Given this list of marker genes Cd47, Hspa1a (NCBI Gene Id 193740), Fos, Grap, Rabgap1l, Evl, Mxd4, Arhgap15, Cmah, Rgs10, Txnip, Cirbp, Ifngr1, Txk, Npc2, Pdcd4, Smc4, 9930111J21Rik2, Pik3ip1, Tmem50a, Hspa1b, Rapgef4, Jak1, Myl12b, Stk4, AB124611, Klhl24, Klf6, Sell, Zbtb20, Map4k4, Ube2b, Hp1bp3, Cdkn1b, Lsp1, Hcst, Epsti1, Kif21b, Chd2, Bnip3l, Rhoh, Cd3g, Dapl1, Akap13, Tcf7, Ppp1r15a, Jmjd1c, Klf2, Itga4, Madd, Btg2, Smap2, H1f2, Pcmtd1, Zfp36l2, Atp1b3, Eef1a1, S1pr1, Cd8b1, Slfn2, Tent5a, Plcxd2, Mgst2 (NCBI Gene Id 211666), Ets1, Acp5 (acid phosphatase 5, tartrate resistant), Tmem59, Fam169b, Crip1, Gpx4, Peli1, Cdkn2d, Il7r, Tnrc6b, Ccr9, Jun, Ypel3, Entrep3, Ighm, Smad7, Crlf3, Arhgap45, Dap, Rnf167, Gmfg, Actn1, Saraf, Stk38, Stim1, Zfp36l1, Pnrc1, Scp2, Klrd1, Cd7 (CD7 antigen), Tmem71, Jakmip1, Arl5c, Utrn, Klf3, Tcp11l2, Gimap1, Fau, Rasgrp2, Itm2b, Smpdl3a, Paip2, Fyb1, Cox7a2l, S100a10, Vgll4, Add3, Grap2, Junb, Tspan32, Adcy7, Macf1, Emp3, H2az2, Slamf6, Tsc22d3, Ptpn18, Lef1, Tspo, Sh2d1a, Pold4, Themis, Dguok, Dgka, Selplg, Cd69, Ltb, Btg1, Cxcr4, Cd28, here is a description of the gene set: Genes negatively differentially expressed in cell type: CD8+ T cell upon treatment with cytokine: IL-2 in mouse lymph nodes in vivo. studied in species Mus musculus Cytokines mediate cell-cell communication in the immune system and represent important therapeutic targets. A myriad of studies have highlighted their central role in immune function, yet we lack a global view of the cellular responses of each immune cell type to each cytokine. To address this gap, the authors created the Immune Dictionary, a compendium of single-cell transcriptomic profiles of more than 17 immune cell types in response to each of 86 cytokines (>1,400 cytokine-cell type combinations) in mouse lymph nodes in vivo. A cytokine-centric view of the dictionary revealed that most cytokines induce highly cell-type-specific responses. For example, the inflammatory cytokine interleukin-1β induces distinct gene programmes in almost every cell type. A cell-type-centric view of the dictionary identified more than 66 cytokine-driven cellular polarization states across immune cell types, including previously uncharacterized states such as an interleukin-18-induced polyfunctional natural killer cell state. from publication Cui A, Huang T, Li S, Ma A, Pérez JL, Sander C, Keskin DB, Wu CJ, Fraenkel E, Hacohen N (PMID 38057668) Mouse Gene Set: CUI_T_CELL_CD8_IL2_RESPONSE_DN